The following is a description of a gene set: studied in species Homo sapiens Eukaryotic centromeres are marked by a unique form of histone H3, designated CENPA in humans. In human cells newly synthesized CENPA is deposited in nucleosomes at the centromere during late telophase/early G1 phase of the cell cycle. Once deposited, nucleosomes containing CENPA remain stably associated with the centromere and are partitioned equally to daughter centromeres during S phase. A current model proposes that pre-existing CENPA at the centromere drives recruitment of new CENPA, however this has not been proved.<br>The deposition process requires at least 3 complexes: the Mis18 complex, HJURP complex, and the RSF complex. HJURP binds newly synthesized CENPA-H4 tetramers before deposition and brings them to the centromere for deposition in new CENPA-containing nucleosomes. The exact mechanism of deposition remains unknown. part of: Nucleosome assembly Reactome Pathway: Deposition of new CENPA-containing nucleosomes at the centromere, and this is the list of marker genes: H2BC4, H2BC15, H4C1, CENPN, CENPM, CENPL, H2BC13, CENPA, H2BC5, H2AC14, HJURP, NPM1, RSF1, RBBP4, H2BC14, CENPQ, MIS18A, H2BC3, H2AJ, H2BC12L, SMARCA5, H2AZ2, H2BC17, H2BC1, CENPH, CENPW, H2AX, RBBP7, ITGB3BP, CENPT, H2AC6, H2BC9, RUVBL1, CENPI, H2BC12, H2AC7, CENPX, CENPU (centromere protein U), CENPO, KNL1, CENPC, CENPS, H2AC4, OIP5, CENPK, CENPP, H2AC20, H2AB1, MIS18BP1, H2AC18, H2BC26, H2BC11, H2BC21